Given this list of marker genes PLEC, TNFRSF1A, FGFR3, RET, SLX4, SHOC2, CLCN7, CDKN2B, NF2, RAD51, CYBC1, MED12, EP300 (E1A binding protein p300), CBL, ABCC9, KLLN (NCBI Gene Id 100144748), SPRED1, COPB1, FANCD2, TSC1, MAD2L2, ACP5, SMARCA2, GJA1, MAPK1, ZMPSTE24, DKC1, ST3GAL5 (ST3 beta-galactoside alpha-2,3-sialyltransferase 5), PCNT, SVBP, SKIC2, GPNMB, VHL, CYBB (cytochrome b-245 beta chain), FANCG, ERCC1, IFNG, XPA, ATP2A2, TSC2, KMT2D, POLE, ERCC8, KRT14, TOMM7 (NCBI Gene Id 54543), RFWD3, IL6, POGLUT1, PRKAR1A, DDX11, CHD8, PPP1CB, CEP57, KDM5C (NCBI Gene Id 8242), KDM6B (lysine demethylase 6B), TMEM127, WASF1, GNAS, STEAP3, BRCA2, GJB3, TMC6, MLH1, FANCF, SET, USF3, BPTF, BLM, TINF2, APC, MAP2K1, FANCE, SEC23B, PMS2, KDM6A, ESCO2, TAF4, WBP11, NCF2, HEPACAM, PLXND1, BUB3, DHX30, MSH6, RAD51C, RBBP8, MAN1B1, KIT, NPM1, CREBBP, PALB2, USB1, CDKN2C, FANCA, BRCA1, SKIC3, CTC1, HMGA2, MAX, KRAS (NCBI Gene Id 3845), SMARCAL1, SDHB (succinate dehydrogenase complex iron sulfur subunit B), LMNA, TMC8, KANSL1, ABCB6, TYMS, UBR1, NCF1, RTEL1, WRAP53, BUB1B, TWIST2, AKT1, PDE11A, CYBA, ARL6IP6, SASH1, TERC, SDHC, TP63 (NCBI Gene Id 8860), ERCC6, BRAF, IGF2, GNA11, POFUT1, SLF2, LZTR1, ANKLE2, XRCC2, CDKN1C, NHP2, IL7, CAPRIN1, H4C5, IRF1, FANCL, GNAQ, PSENEN, TOP3A, CWC27, SMARCAD1, NOP10, PHIP, NCF4, KDSR, KITLG, TRIP13, ATM, ERCC2, CDKN1B, INSR, REV3L, NRAS, MAP2K2, RAF1, ERCC4, FANCB, SDHD, KRT5, SH3PXD2B, ANAPC1, PIK3CA, UBE2T, TP53RK, STK11, XPC, C1R, DDB2, C1S, CDKN1A, FANCC, MEN1, UBAP2L, COL17A1, ERCC5, MSH2, SOX10, NBN, PTEN, MTOR, ACTB (actin beta), PTPN11, DSTYK, FANCI, GJB4, SLC9A1, FANCM, GNB2, RFX7 (NCBI Gene Id 64864), BUB1, CIB1, BRIP1, PLAG1, NF1, ERCC3, IGF1, PARN (poly(A)-specific ribonuclease), RERE, MMP2, TERT, here is a description of the gene set: Hypermelanotic macule Human Gene Set: HP_HYPERMELANOTIC_MACULE species: Homo sapiens A hyperpigmented circumscribed area of change in normal skin color without elevation or depression of any size.